Given this list of marker genes CD81, TRIM25, SLC35D2, ZBTB4, NCK2, DMD (NCBI Gene Id 548327), PANK1, PLD3, CSNK1E, ACTN1, CAVIN1, PRDX2, ZNF862, PLEKHA2, TIE1, LAT, HOXB4, TRIB3, PTPN12, DEXI, IL17RE, NBDY, CLNK, XRCC5, LTBP3, STXBP1, BEST1, PABPC4L, NKX2-3, NSMF, RRAS, MFSD6, FCHSD1, GIT2, KLHDC1, ZNF287, SLC12A7, HS6ST1, PHETA2, PAK1, GIMAP8, INPP5B, ABHD4, SNX33, ATP8A1, SIGIRR, PRXL2A, SLC26A2, ADCY9, CD200, GBP7, ZDHHC17, CREBL2, TMEM40, TPRG1L, GSN, CCDC120, FMO5, MBD6, ARID1B, ATAT1, GARRE1, KRBA1, MEIS1, ARSK (NCBI Gene Id 153642), ZNF329, PLCG1, CERS4, CTDSP2, BACH1, IFIH1, TFR2 (transferrin receptor 2), CA1, BAHCC1, PLAAT3, NCAM2, PHLPP1, CSAD, ARHGAP25, SSBP3, MTURN, RAB38, CHD2, BRPF3, GRB10, NEXN, SLC7A8, H1-0, CXXC5, MFSD13A, CSGALNACT1, UPP1, ANXA11, WDFY3, GRAMD1A, GLUL, HYCC1, MBLAC2 (metallo-beta-lactamase domain containing 2), NFIC, ATP2B4, PHC1, DYNLT3 (NCBI Gene Id 6990), AIPL1, GTPBP2, LGR5, RBMS2 (RNA binding motif single stranded interacting protein 2), SMARCC2, TRAF1, CCSER2, SIK3, FZD6, UBP1, ELAVL3, SMAP2, IRAK3, RPS18, RAI1, ISG20, DNMT3B, AAMDC, ADGRL1, TRAPPC9, MMRN1, FAHD2A, IER5, ZNF827, SIPA1L3, GIMAP1, TRIP6, MVP, KIAA1958, VAMP5, ST6GALNAC5, KCND1, BCORL1, GDPD1, RBM4B, RNASE6, ZNF551, APOE, ZNF319, SDSL, SMAD3, FZD7, SIX5, LTB, ASAH2, KHNYN, CTTN, TMT1A, SLC18B1, MRTFB, ZMYND8, PGLYRP2, EPC1, GSK3A, ITGA2B (NCBI Gene Id 3674), LDHD, KAZN, PDLIM2, LYPD6B, STIM1, NFKBIZ, GPR155, AGO1, F2R, PARM1, C12orf75, PTTG1IP, ELL2, SHISA5 (shisa family member 5), GIGYF1, STX17, CHD6, MMP2, NFIA, OPTN, ABCG2, EYA2, LARGE2, KCNJ10, ELL, GNS, CCDC112, ADGRL2 (adhesion G protein-coupled receptor L2), PISD, IFI27 (interferon alpha inducible protein 27), CLIC5, MIDEAS, CYP4V2, PML, ACOT11, IFIT1B, JUND, SGCE, SOAT2, MYH10, HID1, here is a description of the gene set: Human Gene Set: GSE22229_RENAL_TRANSPLANT_VS_HEALTHY_PBMC_DN from publication Newell KA, Asare A, Kirk AD, Gisler TD, Bourcier K, Suthanthiran M, Burlingham WJ, Marks WH, Sanz I, Lechler RI, Hernandez-Fuentes MP, Turka LA, Seyfert-Margolis VL, Immune Tolerance Network ST507 Study Group (PMID 20501946) species: Homo sapiens Genes down-regulated in periperal blood monocytes (PBMC): tolerant kidney transplants versus healthy controls. In this study, investigators recruited the largest reported cohort of tolerant kidney transplant recipients who maintained their graft after ceasing to take their immunosuppression drug, and compared this cohort to subjects with stable allograft function while on immunosuppression and healthy non transplated, controls. Using gene expression studies, they identified genetic markers that are strong candidates for predicting kidney transplant candidates who may benefit from minimization or withdrawl of immunosuppression. Microarrays were used to detect expressed gene profiles of whole-blood total RNA from subjects in the tolerant, standard immunotherapy and healthy control participants